The following is a description of a gene set: A structural framework, or 'dense core' at the interior of an acrosome. May regulate the distribution of hydrolases within the acrosome and their release during the acrosome reaction. Mouse Gene Set: GOCC_ACROSOMAL_MATRIX studied in species Mus musculus, and this is the list of marker genes: Acr, Zp3r, Cylc1, Dld, Spaca3